The following is a description of a gene set: studied in species Homo sapiens Genes predicted to be targets of miRBase v22 microRNA hsa-miR-11400 in miRDB v6.0 with MirTarget v4 prediction scores > 80 (high confidence targets). from publication Chen Y, Wang X (PMID 31504780) Human Gene Set: MIR11400, and this is the list of marker genes: CAD, SPRYD3, TAF4, SPAST, TMC4, UBAP2L, NEURL2, EDEM3